The following is a description of a gene set: Any process that modulates the frequency, rate or extent of ERAD pathway. Human Gene Set: GOBP_REGULATION_OF_ERAD_PATHWAY species: Homo sapiens, and this is the list of marker genes: AQP11, RNF185, XBP1, USP19, BAG6, USP13, NFE2L2, USP25, UBQLN1, TMEM259, SGTA, SVIP, ATXN3, HERPUD1, UBQLN2, USP14, STUB1, UBXN1, UBXN2A, CAV1, TMX1, WFS1, ATXN3L, RNFT2, RNFT1, BCAP31